Given this list of marker genes MSN, JAM2, NR4A3, S100A8, ZAP70, STK10, CD44, S100A9, RAC2, IL1B, BMP7, SEMA4D, HAS2, here is a description of the gene set: species: Homo sapiens The adhesion of one leukocyte to one or more other leukocytes via adhesion molecules. Human Gene Set: GOBP_LEUKOCYTE_AGGREGATION